Given this list of marker genes Mad2l2, Poli, Sprtn, Ube2v2, Dtl, Polk (polymerase (DNA directed), kappa), Pold3, Brca1, Polq, Ube2v1, Vcp, Pole2, Msh2, Poln, Pold1, Zbtb1, Pclaf, Pcna, Parp10, Rad18, Pold2, Primpol, Polh, Ube2b, Faap20, Rev1, Aktip, Poldip2, Rev3l (REV3 like, DNA directed polymerase zeta catalytic subunit), Ube2n, here is a description of the gene set: studied in species Mus musculus Mouse Gene Set: GOBP_POSTREPLICATION_REPAIR The conversion of DNA-damage induced single-stranded gaps into large molecular weight DNA after replication. Includes pathways that remove replication-blocking lesions in conjunction with DNA replication.